The following is a description of a gene set: species: Homo sapiens from publication Chen Y, Wang X (PMID 31504780) Genes predicted to be targets of miRBase v22 microRNA hsa-miR-3614-3p in miRDB v6.0 with MirTarget v4 prediction scores > 80 (high confidence targets). Human Gene Set: MIR3614_3P, and this is the list of marker genes: RNF38, SMG7, DCLK1, CIBAR1, PTPRD (NCBI Gene Id 5789), GOLT1B, BBX, DCAF7, KCNRG, ECT2L, TAPT1, ZBTB10, FBLN5, AKAP9, RAB7A, EXOSC7 (NCBI Gene Id 23016), FOXO4, HS3ST4, KRR1, NUP50, IGSF11, EID1, ULK4, SALL4, CLDN8, MPZL2, KCTD6, MBNL3, GRAMD1B, CEP97, NFIB, WFDC6, PTPRJ, OSER1, KLHL34, PTPDC1, ECHDC1, FAM120A, CDH6, ATP11B, LIMS2, RNF19A, SYT9 (synaptotagmin 9), SRRM4, DDHD1, FAR1, NIPSNAP3A, CCL26, TNFAIP8, CCNT2, ZBED5, ACTB, NF2, FKBP10, PJA2, KHNYN, DGCR8, PIK3R1, AKT3, PCDH19, CPEB3, MAP2, BCL2L15